Given this list of marker genes RNMT, TIAM1, LMO2 (LIM domain only 2), SLPI (NCBI Gene Id 6590), RHOU, ANKH, PIP4P1, ARHGAP26, PAPSS2, GLIPR1, ASNSD1, CDS1, PTPN18, UQCC5, CRIP1, LZTFL1, GAMT, TNS3, COMT, BPHL, RASSF4, NPM1, PLD1 (phospholipase D1), IDH1, APH1B, LAMTOR4, SLC9A9, FRMD4A, SLC39A10, FAS, TOR3A, ETHE1, COX6B2, SUB1, MX1 (MX dynamin like GTPase 1), PRKRA, IFITM3, XRCC4, AHNAK, PIK3R2, SEC24D, CASP6, SIRT2, RAB11FIP5, NMRAL1, SERP1, ZNF385A, GLIPR2, CDK16, TYK2, PNP (NCBI Gene Id 4860), RAB3D, MEFV, PSMA4, F10, SLC36A1, TEP1, DYNLT2B, TMED10, CTSV, CTSH, RWDD2A, LRWD1, ITPR1, ZCCHC24 (zinc finger CCHC-type containing 24), FUOM, ANXA2, ADAM19, TGFBI, ANKLE2, TRAPPC2L, ARHGEF6, DCXR, SNX9, ANXA5, TNFSF14, ACAT1, IGBP1, APRT, NCEH1, TMEM86A, SRD5A3, CDK5RAP3, ADK, ATAD2B, PI16, TMEM154, INSR, ARID5A, SEC61A1, MTMR10, MAN2A2, SLFN5 (NCBI Gene Id 162394), PRDX4, PPP1R21, SSBP2, FRMD4B, PPP1CA, CTDSP2, IFT57, TMEM184B, APLNR, TXN2, GALNT9, TMEM165, PKIB, IGSF8, GRAMD2B, QPCT, WIPF1, SMIM6, MOCOS, ANXA1, H2AZ1, PSMA7, TFDP1, HIVEP3, EEIG2, SLC25A4, HMG20A, EPSTI1, MZT2B, CFAP410, ESYT1, KIF9, HIGD2A, PTRHD1 (NCBI Gene Id 391356), LMO1, CD302, RGS10, EIF4E3, PIK3R6, PPFIA4, UNC119B, SMDT1, CTSC, SIRT3, TTC39C, S100A6, GLRX3, BTF3, NOTCH1, ERP29, TMEM268 (NCBI Gene Id 203197), AGRN, SLC25A12 (NCBI Gene Id 8604), RNASEL, STX3, ABTB1, SEC61B, GALNS, CUTA, PGLS, RP9 (NCBI Gene Id 6100), IFI30, SLC45A4, GLB1, CLEC4A, EIF2A, TCP11L2, IAH1, CD33, IKBKE (inhibitor of nuclear factor kappa B kinase subunit epsilon), ATP5F1C, MYO5A, BSCL2, ADAM15, BTLA, TTC13, ACAA1, SIDT2, CCR2, GNPAT, SPTSSA, MTHFR, AMPD2, GPX4, ATP6V1B2, RCSD1, NIT2, EVA1B, INF2, EPRS1, TMEM107, SELENOP, VIM, TREM2, FARS2, KLHL6, SELL, TESK2, KIAA0040, TMEM205, DPY19L1, GBP7, NCBP2AS2, MINDY1, STOM, IQGAP2, CAPN2 (NCBI Gene Id 824), here is a description of the gene set: studied in species Homo sapiens Human Gene Set: GSE26030_UNSTIM_VS_RESTIM_TH1_DAY5_POST_POLARIZATION_DN Serial comparison between Th1 and Th17 tumor-specific cells cultured in vitro and ex vivo after transferred into sublethaly irradiated B6.PL mice. Th17-derived cells acquire Th1-like properties in vivo but maintain a distinct molecular profile. Genes down-regulated in Th1 cells 5 days post polarization: control versus stimulated with anti-CD3 and anti-CD28. from publication Muranski P, Borman ZA, Kerkar SP, Klebanoff CA, Ji Y, Sanchez-Perez L, Sukumar M, Reger RN, Yu Z, Kern SJ, Roychoudhuri R, Ferreyra GA, Shen W, Durum SK, Feigenbaum L, Palmer DC, Antony PA, Chan CC, Laurence A, Danner RL, Gattinoni L, Restifo NP (PMID 22177921)